Given this list of marker genes NFIL3, CD2, CRYGB, BMAL1, INPP4A, IGHA1, SMARCB1, AFDN, NEK6, PRKCI, LYPLAL1, GRAMD1C, IL6R, SMCO4, ARSA, P2RY12, KLHL6 (kelch like family member 6), COL4A4, FAS, ATP2B4, UNC50, PAPSS1, DCAF17, ACSL1, SRGN, RAB25, SLC16A6, SINHCAF, CALM2, SLC2A1, SLC35D2, RPL23, TRAF1, CD58, NSD2, HERPUD1, CDC42EP3, NABP1, EMP3, ZNG1A, ROBO3 (NCBI Gene Id 64221), CALHM2, CD82, BHLHE41, SDR16C5, RASSF6, VIM, GCLC, SYBU, COMTD1, PHACTR2, GPR183, AHNAK, DAAM1, FAIM, SCPEP1, TIGD3, RNGTT, GPR34, IGSF10, NAB1, TBC1D9 (NCBI Gene Id 23158), CAPN2, CLIP2, SLC27A3, GUCY2C, PIK3R6, PRKACB (NCBI Gene Id 5567), EFHC1, CPXM1, CCDC126, LMO4, SHISA8, MGAT4A, SLC27A4, OSBPL3, APH1B, ASCL2, SERPINA9, POU6F1, UBE2G1, PLP2, KYNU, CDKN2C, ABCA6 (NCBI Gene Id 23460), TNFSF11, KCNMA1, DENND1B, ANTXR2, PLEK, STK38L, MPZL1, SSPN, CCDC141, TSC22D1, SPAG5-AS1, ZCCHC4, TWSG1, ITGAM, GFOD1, KCNH2 (NCBI Gene Id 4027), ZDHHC13, SLC66A3, SMIM14, VAMP1, GFPT1, PARPBP, PTAFR, CTSH, CISD3, CRACR2B, GRAMD4, TARBP1, ENTPD4, ITGB1, LGALS1, SND1, TBK1, SLC35D1, CLIP4, CD80, WEE1, HSPA6, ZBTB20, CCDC85C, RNASE4, CDC42SE2, PARP4, TRERF1, OSBPL10, CREBL2, C1RL, MUC20, TMEM59, MS4A7, RIC8B, NAAA, FOLR1, SLC9B2, CEP15, IMPDH1, ZNF565, ALOX5AP, BMPR1A, TRAC, IL2RB, RDX, PTCH1, RORA, TEX9 (NCBI Gene Id 374618), SNHG32, SAMSN1, RAD17, CCR1, PDE4D, FGD6, TMEM65, ARL2BP, CORO1B, PASK, CIDEB, RNF19B, GSTK1, CRYBG1, DCAKD, CD81, LPCAT4, PAG1, CPNE5 (copine 5), ANXA2, IER5, TMEM14A (NCBI Gene Id 28978), DGKE, PRKCH, TESC, CEBPG, POU2AF1, CLIP1, MAF, KCNN4, SCGB2A2, NOL4L (nucleolar protein 4 like), ITPRIPL2, ATXN1, DND1, VPS37A, DBH-AS1, CD27, ZNF185 (NCBI Gene Id 7739), RALGPS1, CRTAP, SLC22A18, BTNL9, here is a description of the gene set: from publication Longo NS, Lugar PL, Yavuz S, Zhang W, Krijger PH, Russ DE, Jima DD, Dave SS, Grammer AC, Lipsky PE (PMID 19023113) species: Homo sapiens Genes down-regulated in comparison of naive B cells versus memory B cells. Sorted B cells using flow cytometry. CD19 selected B cells were sorted using flow cytometry. Human Gene Set: GSE12366_NAIVE_VS_MEMORY_BCELL_DN